Given this list of marker genes Atp2b1, Atp2a1, Atp2b4, Calm1, Atp2a3, Atp2b3, here is a description of the gene set: electronically inferred by orthology from the curated human pathway species: Mus musculus This event has been computationally inferred from an event that has been demonstrated in another species.<p>The inference is based on the homology mapping from PANTHER. Briefly, reactions for which all involved PhysicalEntities (in input, output and catalyst) have a mapped orthologue/paralogue (for complexes at least 75% of components must have a mapping) are inferred to the other species. Reactome Pathway: Reduction of cytosolic Ca++ levels part of: Platelet calcium homeostasis